The following is a description of a gene set: Neurotransmitter receptor activity occurring in the postsynaptic membrane that is involved in regulating postsynaptic membrane potential, either directly (ionotropic receptors) or indirectly (e.g. via GPCR activation of an ion channel). Mouse Gene Set: GOMF_NEUROTRANSMITTER_RECEPTOR_ACTIVITY_INVOLVED_IN_REGULATION_OF_POSTSYNAPTIC_MEMBRANE_POTENTIAL species: Mus musculus, and this is the list of marker genes: Gria3, Chrna7, Chrna2, Chrnb2, Gabrg2, Grid1, Grik3, Chrnb3, Grin3a, Chrna4, Chrnb1, Chrna6, Grin1, Gabra6, Chrnd, Grin2d, Chrne, Glra2, Gabra2, Grin2c, Chrna5, Grid2, Gabrb3, Gabre, Gabra5, Kctd12, Gria4, Grin3b, Gabra4, Chrna1, Grin2b, Glrb, Gabra1, Grik2, Grin2a, Gabrb2, Grik5, Chrna10, Grik1, Gabbr1, Htr3a, Htr3b, Grik4, Gabrb1, Chrng, Gabra3, Kctd16, Gabrd, Gria2, Gabrr2, Adrb1, Chrna9, Gria1, Gabrg3, Chrnb4, Glra1 (NCBI Gene Id 320836), Chrna3